Given this list of marker genes PCDHA5, ID2, DCAF4, OR6B1, BAIAP3, OCIAD2, DNAJC6, XIRP2, SKIL, SNORD114-3, SLC7A7, ZNF440, TMEM213, HHIP-AS1, LINC00661, ENSG00000267882, PMEPA1, CNIH2, HDGFL1, OR7A17, FGD5, FST, ID2B, SPIN4, SPOCK1, CHMP4C, AMIGO2, KCNQ5, WDFY2, TFDP3, INSL6, USP54, C22orf42, RPL10P17, GXYLT2, RAG2, LIPI, APOC1, LINC02880, TEX26-AS1, DNAH17-AS1, RSPO4, SLC25A22, FAM83G, TMEM252, DEFT1P, DSCAM-AS1, LINC02961, SYCP2 (synaptonemal complex protein 2), ZKSCAN7, CRTC3, PADI2, CCDC9B, MMRN1, UBXN1, AKR1C3, KCNJ2, SLFNL1, TEX35, CMTM2, LZTS2, POLL, DIO3OS, EPHA7, PHF7, MTHFD1L, MSN, C12orf60 (chromosome 12 open reading frame 60), PHLDA3, TRPM3, TTF1, KATNAL2, PDLIM7, RENBP, DEGS2, GLI4, HBEGF, ZNF229, KLHL4, MINK1, OCEL1, MRRF, BAZ2A, ZNF225-AS1, PLPPR2, VSIG10, SH3BP4, PARP15, GCHFR, AQP10, MZF1-AS1, PTPRN (NCBI Gene Id 5798), DNASE2, FOXP4, TLR7, INMT, SLC46A2, TBC1D22A-AS1, MYF6, ACTL10, MAP4K1, LSM11, FMO5, CDK15, MIR1-1HG, GPR137C, KCNK17, CDH2, C12orf56, RIBC1, LACRT, TMEM92, CCDC120, ATP6V1E2, CA13, SLC6A4, CFHR2, INA, HRC, ABCG5, SPIN1, MRNIP, PGA3, ID3, RMDN3, ZBTB8A, BIN2 (bridging integrator 2), KCNAB1, ZSCAN2, TCERG1L, OSBPL1A, SNAI3, PCNX2, TMEM100, SH2D3C, SPANXA2-OT1, ZNF480, GBGT1, LINC00635, LRRC39, ACOX1, KLRC4 (killer cell lectin like receptor C4), CNNM2, USP11, TAS2R50 (NCBI Gene Id 259296), ZNF713, HAPLN1, PCGF3-AS1, LINC00529, ALOX5AP, DENND11, PALD1, LINC01144, RASGRF2, HPN, ERCC6, EFNB3, ENSG00000258525 (NCBI Gene Id 100506071), MTMR11, KRT6A, EPM2A, MOXD1, SERPINA12, SMAD7, ULBP1, SMAD6, PKD1L1-AS1, LEFTY2, SLC38A11, SCN4B, HLMR1, SCMH1, MAP3K20-AS1, RAB9B, ADSS1, SPATA17, DSCR10, SORL1, CFAP96, ADAMTSL5, HAMP, EFNA4, SKI, ALDH2, HABP4, TCF7L2, MAGI2-AS3, MAGI1, RBL2, GALNT10, SYNE3, CEBPA, PLK1, INGX, VN1R2, here is a description of the gene set: studied in species Homo sapiens Genes up-regulated in T cells: control (0h) versus IL21 treatment for 1h. from publication Kwon H, Thierry-Mieg D, Thierry-Mieg J, Kim HP, Oh J, Tunyaplin C, Carotta S, Donovan CE, Goldman ML, Tailor P, Ozato K, Levy DE, Nutt SL, Calame K, Leonard WJ (PMID 20064451) Human Gene Set: GSE19198_CTRL_VS_IL21_TREATED_TCELL_1H_UP Interleukin-21 (IL-21) is a pleiotropic cytokine that induces expression of transcription factor BLIMP1 (encoded by Prdm1), which regulates plasma cell differentiation and T cell homeostasis. We identified an IL-21 response element downstream of Prdm1 that binds the transcription factors STAT3 and IRF4, which are required for optimal Prdm1 expression. Genome-wide ChIP-Seq mapping of STAT3- and IRF4-binding sites showed that most regions with IL-21-induced STAT3 binding also bound IRF4 in vivo, and furthermore, revealed that the noncanonical TTCnnnTAA GAS motif critical in Prdm1 was broadly used for STAT3 binding. Comparing genome-wide expression array data to binding sites revealed that most IL-21-regulated genes were associated with combined STAT3-IRF4 sites rather than pure STAT3 sites. Correspondingly, ChIP-Seq analysis of Irf4_/_ T cells showed greatly diminished STAT3 binding after IL-21 treatment, and Irf4_/_ mice showed impaired IL- 21-induced Tfh cell differentiation in vivo. These results reveal broad cooperative gene regulation by STAT3 and IRF4.